Given this list of marker genes PLCG1, TPST2, CYFIP1, LZTS3, SESN3, SELENOT, ARHGAP4, TMEM245, SAR1A (secretion associated Ras related GTPase 1A), SMPDL3A, KLF13, TAF13, STK10, MYO18A, EARS2, TTLL3, SYK, KHNYN, ELL3, RBMS1, TFEB, ACTRT3, DDX50, FBXL17, CC2D1B, UBALD1 (NCBI Gene Id 124402), SSH2, TAF5L, LLGL1, TBC1D20, METAP1D, COQ10A, FGD6, CDC42BPB, AKAP13, ACKR2, ATOSB, PHF21A, SELENOK, RNF167, NDST1, SGMS1, SF3B1, TSR2, RPS27 (NCBI Gene Id 6232), USP6NL, MBTD1, CREBBP, E2F5, MTURN, UAP1, ANKRD44, PAFAH1B1, SAG, ADD3, ANXA1, SCD, BCL7B, GRAMD2B, TLN1, PCM1, NHLRC3, RCSD1, MAU2, ASAP2, TLE1, NXF1, NPC1, PNISR, MYH9, REL, TOP3B, SZT2 (NCBI Gene Id 79597), CXXC5, BTLA, UBN2 (NCBI Gene Id 254048), TTC19, MACIR (macrophage immunometabolism regulator), COQ8B, RAB33B, ENDOD1, CRIM1, GIGYF1, VPS39, TTC5 (tetratricopeptide repeat domain 5), CDKN1B, TUT7, NUMB, WASL, SNX30, FGD2, CALCRL, SKI, SIPA1L3, ERP27, SRSF11, TSPAN13, GIMAP6, CEP70, LEMD2, BCAS3, DENND5A, FAM193B, CHSY1, TRIM11, NKTR, SFT2D1, NFKB1, MAFG (NCBI Gene Id 84797), SIDT2, RASGRP1, INTS6L, MMAA, MAP1LC3A, PPOX, FOXN3, DVL1, CERK (NCBI Gene Id 64781), BRD4, RNF125, NCOA3, CPM, RAB11B (RAB11B, member RAS oncogene family), PRAMEF8, DYNLT3, HNRNPDL, MARCHF3, CYRIB, TPCN2, SIPA1, TOLLIP, AZI2, DUSP6, VPS37A, CIPC, PCMTD1, RSRC1, CUX1, AFF4, IQSEC1, MTMR3, UBL3, VAMP3, FAM120AOS, CYRIA, AP2A2, NIPSNAP3A, FAM13B, ATXN7, CLK4, NCOA6, AFF1, SF1, MKNK1, N4BP3, TPRG1L, GNL3L, CCDC9, TTLL1, RAB4B, NSD1, SBNO2, STAG2, RIPOR2, TMEM268, MINK1, CBL, AP1S2, CDKN2AIP, CHD6, DDX23, KLHL17, DUSP18, GLS, SMC6, CHMP1B, ATP1B1, IL10, MLXIP, HPS3, NECAP1, KCTD12, CDC37L1, FBXO30, SLC9A8, PIKFYVE, ATG101, DMTF1 (cyclin D binding myb like transcription factor 1), KIF21B, TRIM44, ZNF148, EIF1, INPP5F, ITPKC, DENND6B (NCBI Gene Id 414918), NR3C1, STX17 (syntaxin 17), FKBP7, SH3PXD2A, C1orf54, here is a description of the gene set: species: Homo sapiens During acute viral infections, naïve CD8+ T cells differentiate into effector CD8+ T cells and, after viral control, into memory CD8+ T cells. Memory CD8+ T cells are highly functional, proliferate rapidly upon reinfection and persist long-term without antigen. In contrast, during chronic infections, CD8+ T cells become “exhausted” and have poor effector function, express multiple inhibitory receptors, possess low proliferative capacity, and cannot persist without antigen. To compare the development of functional memory T cells with poorly functional exhausted T cells, we generated longitudinal transcriptional profiles for each. Human Gene Set: GSE41867_NAIVE_VS_DAY15_LCMV_EFFECTOR_CD8_TCELL_DN from publication Doering TA, Crawford A, Angelosanto JM, Paley MA, Ziegler CG, Wherry EJ (PMID 23159438) Genes down-regulated in CD8 T cells: naïve versus effectors at day 15.